Given this list of marker genes Cryaa, Gm37359, Gm33206, Cryge, Hr, Tmprss11d, Mip, Gm20757, Cryga, Gja8, Or8j3c, Bfsp2, Cryba1, Gm31816, Crybb3, Cryba2, Capn3, Sipa1l3 (NCBI Gene Id 74206), Crygn, Oxct1as, Cpne7, Gja3, Pip5kl1, Gm16159, Bfsp1, Gcg, Arsi, Crybb1, Cryba4, here is a description of the gene set: from publication Cao J, Spielmann M, Qiu X, Huang X, Ibrahim DM, Hill AJ, Zhang F, Mundlos S, Christiansen L, Steemers FJ, Trapnell C, Shendure J (PMID 30787437) Mouse Organogenesis Cell Atlas (MOCA) DE_gene_main_cluster.csv, fold.change>=1.5, qval<0.05, pval<0.05 Mouse Gene Set: DESCARTES_ORGANOGENESIS_LENS species: Mus musculus